The following is a description of a gene set: Mouse Gene Set: GOBP_NEGATIVE_REGULATION_OF_HYDROGEN_PEROXIDE_MEDIATED_PROGRAMMED_CELL_DEATH Any process that stops, prevents or reduces the frequency, rate or extent of hydrogen peroxide-mediated programmed cell death. species: Mus musculus, and this is the list of marker genes: Park7, Trap1, Hk3, Rack1, Hgf, Ddr2, Pink1, Met